The following is a description of a gene set: studied in species Homo sapiens Human Gene Set: GATA1_03 Genes having at least one occurrence of the motif ANGNDGATAANNGN in the regions spanning 4 kb centered on their transcription starting sites. This matches the GATA1 transcription factor binding site V$GATA1_03 (v7.4 TRANSFAC)., and this is the list of marker genes: ARHGAP26, CASZ1, ACVR2A, PAPPA, PRDM8, TFAP2D, FBXO11, JPH1, CREB5, WDTC1, ADAMTS6, ELF5, DNAH11, MEF2C, RMI1, GNB1L, ECHDC2, SREK1, RIMS1, GRIN2B, LMO3 (LIM domain only 3), EPO, TTBK2, UBE3A (ubiquitin protein ligase E3A), CALM2, RBPJ (recombination signal binding protein for immunoglobulin kappa J region), DSG4, FOXA1, MEIS2, TMEM255A, RASSF5, GABBR1, S1PR2, CCM2, MBNL1, RAB11A, ADAMTS3, MYRF, RTL10, CA1, KDM6A, ZMYND12, MMP23A, SERPINB6, SP6, ERG, PIM1, PNLIPRP2, ZEB2 (zinc finger E-box binding homeobox 2), ARHGAP15, DOK2, KRT72, RALGPS2, SETD2, EGR2, FEV, SNCA, PNLIPRP1 (pancreatic lipase related protein 1), PRG2, MECOM, ZNF385B, EN1, ZMYM4, LBX1 (NCBI Gene Id 10660), PGGT1B, TWIST1, ZNF485, FOXP1, NCDN, PPP1R16A (NCBI Gene Id 84988), LYL1, GRM1, LTBP1, SLC25A14, BSN, TOB1, SMARCA5, HNRNPK, ZDHHC2, POLD4, AQP4, S100A10, TMEM151A, TNXB, XPO6, ADM, ZNF516-DT, FURIN, SLC9A6, DSPP, SLC4A1, WNT8B, EGLN1, P2RY10, GREM1, TBX19, HOXB6, SSX2IP, TSSK1B, ZMAT4, KCND1, AMOT, ENO2 (NCBI Gene Id 2026), CCL27, FBXL18, HIC1, DMD, IGF2-AS, EFNB1, MID1, TFR2, PTMS, NPL, HOXA7, BNC2, PTCHD4, DLG4, SPAG7, ETV1, TMEM87A, NR3C2, BPGM, FLRT3, LIX1 (NCBI Gene Id 192681, limb and CNS expressed 1), MYO1C, SOX5, LRIG3, OTX2, APTX, ERBB3, PRKCI, GNB3, GATA4, CCDC80, PCDH9, CD40, CNN1, ANGPT2, ADD3, TBX5, UCN2, PCDH7, SIX1, MEA1, EHF, PHOX2B, GPRIN3, RNF144B, STXBP2, SCUBE3, KLF15, BTRC, SFRP5, ZEB1, NF2, ATP13A4, PRRC1, POU2F3, KLF14, RASGRP3, ATXN7L2, PCK1, PPCS, RLIM, NRP2, GATA1, KCNN2, NKX6-2, YBX1, GLI1, WWP2, SRSF1, PITX2, KRIT1, PLAGL2, HABP2, FAM117A, SNX17, FZD4, IGF2, EIF2B4, GREB1, UROD, CRLS1, FAM120C, STAG2, ZIC1, GATA6, ARL4C, CACNA2D3, PCOLCE, ZNF263, POFUT1, HES1, BMP10 (NCBI Gene Id 27302), EGFLAM, MAML3, JUN, MMP16, KLHDC3 (kelch domain containing 3), ITSN2, XIRP1, ADORA3 (adenosine A3 receptor), ZFPM2, EVA1C, DENND1B, GNB5, SYTL2, SOX15, LRGUK, KIRREL2, SERTAD4, TMEM161B, HAMP, ADAMTSL1, UBE2F, IL1RAPL1, FMO4, DCAF7, GBX2, NECTIN4, CTCF, NRAS, CAPN1, HOXC11, YPEL4, CISH, ITGB3BP, CHMP2B, NFE2, RHAG, LHX6, SLC26A9, RASAL2, NDRG2, FOXP3, KRT2, HIVEP3, GABRG2, ELAVL4, GARIN6, POU4F2, OGA, MMP23B, AP2M1, MYBPC3